Given this list of marker genes H2bc11, Mutyh, H2ac7, H2ac20 (NCBI Gene Id 319176), Terf1, H2ac4, H4c14, H2ac11, H2bc22, H2ac12, H2bc3, H4c4, H4c18, H2bc15, H2az2, Acd, H2bc1, H2ac6, H2ac15, Terf2, H2bc12, H2bc7, H4c2, H4c12, H4c6, H2ac22, Mpg, H2bc9, H2bc13, H4c11, H4c3, H4c17, H2bc27, H2ac19, H2ac24, H2ac23, H4c9, H2ac1, H2ax, Ogg1, H2ac13, H4c8, H2bc8, H4c1, H2ac8, H2ac10, here is a description of the gene set: electronically inferred by orthology from the curated human pathway Reactome Pathway: Depurination part of: Base-Excision Repair, AP Site Formation This event has been computationally inferred from an event that has been demonstrated in another species.<p>The inference is based on the homology mapping from PANTHER. Briefly, reactions for which all involved PhysicalEntities (in input, output and catalyst) have a mapped orthologue/paralogue (for complexes at least 75% of components must have a mapping) are inferred to the other species. species: Mus musculus